The following is a description of a gene set: Human Gene Set: TRAVAGLINI_LUNG_SEROUS_CELL from publication Travaglini KJ, Nabhan AN, Penland L, Sinha R, Gillich A, Sit RV, Chang S, Conley SD, Mori Y, Seita J, Berry GJ, Shrager JB, Metzger RJ, Kuo CS, Neff N, Weissman IL, Quake SR, Krasnow MA (PMID 33208946) species: Homo sapiens, and this is the list of marker genes: AZGP1, LPO, WFDC2, XBP1, BAZ2B-AS1, SLPI, BPIFA1, SLC5A1, FKBP11, FUOM, C6orf58 (NCBI Gene Id 389429), PDCD4, LYZ, CA2, PRB3, PPP1R1B, PRH2, DEPTOR, CLDN10, TESC, PART1, CCL28, GPT2, PRB2 (proline rich protein BstNI subfamily 2), SELENOM, PHLDA1, GNAS, PAIP2B, RTN1, LINC01829, FDCSP, BARX2, APIP, CYP4X1, AK4, RBP7, NDRG2, FAM3D, WFDC21P, ELF5, GGTA1, CXCL17, DMBT1, NUCB2, PRB4, S100A1, SMCO4, CRISP3, PHGDH, FAM107B, AQP5, ZG16B, HSD17B2, MIA, KCNN4, SMR3A, S100B (NCBI Gene Id 6285), MARCKSL1, SH3BGRL2, PIP, GATM, ALDH1L1, PRB1, TCN1, MANSC1, PHB1, LTF, PKDCC, SLC13A2, STK39, BPIFB1, PPP1R16A, ATP2A3, SERPINA3, AIF1L, PLTP, ALDH18A1, PYCR1, GCNT3, SSR4, LRRC26, SLC12A2, ELAPOR1, MUC7, SFRP1, PIGR, PRR4, TTYH1, CAPN12, NPDC1, TPD52L1, GMDS, CDC42EP5, PRH1, ODAM, PADI2